Given this list of marker genes KLHL10, ST3GAL1, TOP1, CYS1, MRGPRF, IL23A, MFSD4B, FHL5, IVD, TNNT2, CX3CL1, CCL2, STARD10, LHX5, HOXA7, ST3GAL5, NAA38, YBX2, FOXL1, OPRL1, S100G, KREMEN1 (NCBI Gene Id 83999), PRKRIP1, ZP1, SQSTM1, KLF5, P2RY14, WIPI1, LIF, ACSF2, ELAPOR1, ELF3, WNT7B, MLLT6, SLC41A2, MTDH, YIPF3, FER, FKBP11, TGFB2, STAT5A, IER2, FOXP1, CITED2, PTPN23, CLRN3, SRSF7, DLST, VAV1, CD44, KMO, NSMCE2, JAK2, NRL, DPH6, PHLDA1, RARG, SH3BGR, ARG2, CACNA2D3, TBX5, GRID1, RAB3B, SAMSN1, PRKCZ, TEX12, KIN, DNAJB5, DLG2, GJA4, SPRYD7, ADRB3 (NCBI Gene Id 94406), ZC3H12C, ALPG, FBXW11, TMEM100, PIP5KL1, CD200, KCNK2, GCH1, IGSF8, AREG, HAO2, YRDC, HMGXB3, TNFRSF1B, LCAT, PTGES, SNX10, PLA2G1B, RPL39, BCKDHB, NEAT1 (nuclear paraspeckle assembly transcript 1), MAPK8, C9orf50, SERPINE1, IGF2BP1, ITGA4, CCND2, POU6F1, SCN1A, PCDHA12, DDHD1, CD14, GK, NECTIN2, JARID2, PLK4, SLC44A1, TGM2, IGDCC3, EBF3, RNF149, UGT8, TTC28, HS6ST3, PROCR, CD40, PDCL3, TUBGCP2, IFT81, BCL2L2, SIMC1, BCL2L11, CSF2, MMP12, ITGB3, CYP4F12, PABPC4, MTPN, TECTB, TEX10, MTHFD2, VPS37C, H1-4, CST7 (NCBI Gene Id 8530), MTMR14, SOD2, NUDT9, ANKRD2, ICOS, DLC1, HPCA, SLC39A11, UAP1, PSMA6, RAB17, EHD1, PRICKLE1, RAD18, LENG8, MED25, NTNG1, SOWAHC, SPDEF, FCGR2B, CCDC71L, CHST7, CACNA1A, RUNDC3A, DNASE2B, SLC27A2, FOXI1, CES3, IGSF6, CWC27, CACNA1B, GPR137B, RAB5B, CDK5RAP2, MMP1, NEURL1, ANO10, REPS1, MTMR7, TBK1, CILP2, RNF19A, SH3TC1, ATP6V1E1, PDLIM5, OCSTAMP, SPRY1, LLGL2, FST, IFITM10, F3, EGFR, HES7, LHPP, SUCO, FSCN1, PTPRE, PTPRA, NIBAN1, SRF, ASB15, PPIB, STK17B, DYNC1I1, here is a description of the gene set: species: Homo sapiens Human Gene Set: GSE17721_CTRL_VS_CPG_2H_BMDC_DN Genes down-regulated in comparison of control dendritic cells (DC) at 2 h versus those stimulated with CpG DNA (TLR9 agonist) at 2 h. mouse primary BMDCs were stimulated with tlr ligands and gene expression changes were profiled on Affymetrix arrays from publication Amit I, Garber M, Chevrier N, Leite AP, Donner Y, Eisenhaure T, Guttman M, Grenier JK, Li W, Zuk O, Schubert LA, Birditt B, Shay T, Goren A, Zhang X, Smith Z, Deering R, McDonald RC, Cabili M, Bernstein BE, Rinn JL, Meissner A, Root DE, Hacohen N, Regev A (PMID 19729616)